The following is a description of a gene set: studied in species Homo sapiens Human Gene Set: KEGG_MEDICUS_VARIANT_TGFA_OVEREXPRESSION_TO_PI3K_SIGNALING_PATHWAY TGFA-overexpression to PI3K signaling pathway. Pathway ID: N00232. Pathway type: Variant. Pathway class: nt06260 Colorectal cancer. Pathway Definition from KEGG: TGFA* -> EGFR -> PI3K -> PIP3 -> AKT, and this is the list of marker genes: TGFA, PIK3CB, EGFR, AKT2 (NCBI Gene Id 208), PIK3CD, AKT1 (AKT serine/threonine kinase 1), AKT3, PIK3CA